The following is a description of a gene set: studied in species Mus musculus Mouse Gene Set: REACTOME_ATORVASTATIN_ADME Atorvastatin ADME, and this is the list of marker genes: Ugt1a2, Cyp3a13, Abcb1a, Ugt1a5, Cyp3a11, Cyp3a44, Pon1, Cyp3a59, Pon3, Slco2b1, Abcc2, Cyp3a16 (NCBI Gene Id 13114), Slco1b2, Cyp3a57, Cyp3a41b, Cyp3a41a, Cyp3a25